The following is a description of a gene set: The chemical reactions and pathways resulting in the formation of amino acids containing sulfur, comprising cysteine, methionine and selenocysteine. Human Gene Set: GOBP_SULFUR_AMINO_ACID_BIOSYNTHETIC_PROCESS studied in species Homo sapiens, and this is the list of marker genes: CBS, MTRR, BHMT2, BHMT, GGT1, MTR, CDO1, CTH, ENOPH1, APIP, ENSG00000274276, MTHFD1, ADI1 (acireductone dioxygenase 1)